Given this list of marker genes PDGFB, OSR1, TCF21, LGR4, WT1, EGR1, PAX2, AGTR2, LHX1, RET, PDGFRB, PDGFRA, ADIPOQ, AQP1, CD34, LAMB2, NPHS2, here is a description of the gene set: The progression of the metanephric glomerulus over time from its initial formation until its mature state. The metanephric glomerulus is a capillary tuft which forms a close network with the visceral epithelium (podocytes) and the mesangium to form the filtration barrier and is surrounded by Bowman's capsule in nephrons of the mature vertebrate kidney, or metanephros. Human Gene Set: GOBP_METANEPHRIC_GLOMERULUS_DEVELOPMENT species: Homo sapiens